Given this list of marker genes DYNC1I1, CASP3, RHOT1, RAB3B, RABAC1, RAB7A, SNCA, SYPL1, TUBB3, ATAT1, RAB3A, DYNC2I2, DYNC1H1, TRAK1, MFN2 (NCBI Gene Id 9927), TP53 (NCBI Gene Id 7157), MAP2, DYNC2H1 (NCBI Gene Id 79659), DYNC2I1, BAX, DCTN1, CASP8, KIF1B, DYNC1LI2, here is a description of the gene set: Effects of MFN2 mutation studied in species Homo sapiens Human Gene Set: WP_EFFECTS_OF_MFN2_MUTATION